The following is a description of a gene set: studied in species Mus musculus Mouse Gene Set: GOBP_RESPONSE_TO_BILE_ACID Any process that results in a change in state or activity of a cell or an organism (in terms of movement, secretion, enzyme production, gene expression, etc.) as a result of a bile acid stimulus., and this is the list of marker genes: Alas1, Abcb4, Kcnmb1, Nr1h4, Gpbar1, Vdr, Dgkq